The following is a description of a gene set: Human Gene Set: HP_APLASIA_HYPOPLASIA_OF_THE_SCAPULAE studied in species Homo sapiens Aplasia/Hypoplasia of the scapulae, and this is the list of marker genes: SLC35D1 (solute carrier family 35 member D1), COL2A1, GNPTAB, COL11A2, RSPO2, INPPL1, COL11A1, TBX5, DLK1, RTL1, DYM, SCARF2, RUNX2, PSMB8, ACTB, WDR35, TBX15, PCNT, POR, FGFR3, FIG4, FLNA, TBX3, RIPK4, FGFR1, SOX9, GSC, VAC14, MEG3, NSDHL, TRIP11